Given this list of marker genes EXTL3, HOXA7, ROCK2, ZFP36, SRSF6, PLAAT4, CYP27B1, SGPP1, EZH2, AQP3, TP63, SPRR5, NOTCH1, REG3A, ABCA12, FOXC1, OVOL2, ROCK1, MED1, NME2, KRT84, PKP1, KRT36, ZFP36L1, ALOX15B, TRIM16, NUMA1, ETV4, ZBED2, MSX2, MIR125B1, GRHL1, CD109, ERRFI1, IL20, MACROH2A2, NCOA3, VDR, PRKCH, MACROH2A1, REG3G, here is a description of the gene set: Human Gene Set: GOBP_REGULATION_OF_KERATINOCYTE_DIFFERENTIATION species: Homo sapiens Any process that modulates the frequency, rate or extent of keratinocyte differentiation.